The following is a description of a gene set: Marker genes selected by filtering the centroid data for genes with a value > 0 for the given cell type Human Gene Set: JONES_OVARY_NK_CELL The reproductive and endocrine functions of the ovary involve spatially defined interactions among specialized cell populations. Despite the ovary's importance in fertility and endocrine health, functional attributes of ovarian cells are largely uncharacterized. Here, we profiled >genes in 257 regions from the ovaries of two premenopausal donors to examine the functional units in the ovary. We also generated single-cell RNA sequencing data for 21,198 cells from three additional donors and identified four major cell types and four immune cell subtypes. Custom selection of sampling areas revealed distinct gene activities for oocytes, theca, and granulosa cells. These data contributed panels of oocyte-, theca-, and granulosa-specific genes, thus expanding the knowledge of molecular programs driving follicle development. Serial samples around oocytes and across the cortex and medulla uncovered previously unappreciated variation of hormone and extracellular matrix remodeling activities. This combined spatial and single-cell atlas serves as a resource for future studies of rare cells and pathological states in the ovary. species: Homo sapiens from publication Jones ASK, Hannum DF, Machlin JH, Tan A, Ma Q, Ulrich ND, Shen YC, Ciarelli M, Padmanabhan V, Marsh EE, Hammoud S, Li JZ, Shikanov A (PMID 38578993), and this is the list of marker genes: CALM1, CAV2, FAM43A, ADAMTS5, HLA-E, RARRES2 (NCBI Gene Id 5919), OGN, CFH, CD34, ITGB1, ABLIM1, ITM2A, BNC2, ITGA6, LDB2, EPB41L4A-AS1, NOTCH4, ACTA2, KLHDC8A, S1PR1, FBN1, ESAM, PALMD, PEG3, PDLIM1, COL1A1, CCN2, SMOC2, ACTN4, GIMAP4, UTRN, HLA-C, EGLN1, PREX2, CYB5A, NOTCH3, SPARCL1, HLA-F, ACTB, CCN5, MT2A, MYH9, DSTN, PPP1R12A, IFITM2, SNRK, TPM2, ECSCR, MATN2, ETS1, LBH, PCAT19, LIFR, CRIP2, GUCY1A2, GJC1, MFGE8, PRSS23, COL14A1, GUCY1A1, GJA4, ICAM2, CAV1 (caveolin 1), B2M, CCDC80, NDUFA4L2, SELENOW, PDGFRB, TIE1, PLAC9, ISYNA1, HLA-B, BCAM, COL6A2, MMP23B, CCDC102B, CRIP1, LEPR, SRGN, RAMP2, CTSK, CRIM1, GIMAP7, IGFBP7, COL6A3, HSPG2, ANGPT2, LUM, TGFBR2